The following is a description of a gene set: Human Gene Set: GSE37336_LY6C_POS_VS_NEG_NAIVE_CD4_TCELL_UP The naive CD4 T cell compartment is heterogeneous. Ly-6C- and Ly-6C+ Naive CD4 T cells were compare by microarrays. Genes up-regulated naïve CD4 T cells: Ly6c+ versus Ly6c-. species: Homo sapiens, and this is the list of marker genes: TMSB15A, DYDC2, NALCN, TAMM41, RNF7, SYTL5, TRIB3, IRS2, LINC02995, WDR48, FRG2EP, PUDP, ZNF83, ZNF621, SHOX2, QDPR, VGLL3, GPRASP1, GOLGA2P5, RIPK4, NR2F2-AS1, YTHDC2, SLC2A1, ZNF529, RGS17, ZNHIT3, EZH1, OLIG1, HAPSTR2, CRK, MAGEA6, ANO5, RPS10P7, ARGLU1, PCDH1, SFRP1, SEPTIN6, PTGER4, RAB11FIP5, ZNF700, GPR158, EPHB1, NELL1, SLC47A1, RERG, STAC, PXYLP1 (2-phosphoxylose phosphatase 1), CETN2, TNMD, ZNF655, CXCL1, TEX14, OFD1, TMEM178B, POLR1A, TXLNG, MAGEA3, ENO2, ACSS1, NHS, EDIL3, SH3PXD2A, RPL19, C14orf132, CLDN1 (NCBI Gene Id 9076), VAMP7, CD99P1, DNAJC15, RCAN2, DCBLD2, LINC00667, PEX11B, PIGN, GET1, SPAG5-AS1, KIAA1549, TMEM168, ONECUT2, TOB1-AS1, LINC00665, TMEM183A, ADARB1, LRRN1, ANOS1, HLF, STK24, JPH3, NLGN4Y, SEM1, LINC00839, FAN1, SMS, MORC1, LINC00470, ERVW-1, STS, FAM111A, LINC02035, TIMMDC1, SOHLH2, SMR3B, SDHAP2, ZNF583 (zinc finger protein 583), CXCL8, XK, IL17RB, ATP2B1, CCN3, CFAP74, UGGT2, SOD1 (superoxide dismutase 1), LPGAT1, CEP15, RBBP7, TAF4 (NCBI Gene Id 6874), DPP8, ZNF610, GATA6-AS1, FFAR4, FGF7, PCDH19, CPT1C, BEX2, ASB9, CYB5D2, C3orf49, ARMCX5, TMEM42, BEX1, ARRDC4, PAQR9, CRISPLD2, ENSG00000234352, LRRC37B, CRACR2A, PRRX1, PTCHD1 (patched domain containing 1), PPP1R14C, NUDT16, ENSG00000255647, HAUS1, PALLD, ALCAM, PCCB (propionyl-CoA carboxylase subunit beta), IQCB1, RAB9B, ZNF416, KLHL29, TAC1, GPR85, CHST15, PXDN, MAGI2-AS3, PTCD1, AMBN, TMEM209, KIF26A, ERC1, CMA1, RAB9A, ATF3, LAMP5, HYDIN, ZNF404, C3orf52, IFT52, KIR2DS5, BICDL1, RHEB, CLDND1, ZNF468, TNFRSF11A, MSL3, TMEM200C, SYTL2, CCDC14, PRPH2, DPY19L2P2, VMA21, BCO1, WDR13, FUT4, MORF4L2-AS1, COX17, IL1RAP, LAMP3, NAA16, TCEAL7, TMEM108, SMPX, CXADR, RAB25, FAT1, SERPINI1